The following is a description of a gene set: from publication Moserle L, Indraccolo S, Ghisi M, Frasson C, Fortunato E, Canevari S, Miotti S, Tosello V, Zamarchi R, Corradin A, Minuzzo S, Rossi E, Basso G, Amadori A (PMID 18632618) The side population (SP), recently identified in several normal tissues and in a variety of tumors based on its ability to extrude some fluorescent dyes, may comprise cells endowed with stem cell features. In this study, we investigated the presence of SP in epithelial ovarian cancer and found it in 9 of 27 primary tumor samples analyzed, as well as in 4 of 6 cultures from xenotransplants. SP cells from one xenograft bearing a large SP fraction were characterized in detail. SP cells had higher proliferation rates, were much less apoptotic compared with non-SP cells, and generated tumors more rapidly than non-SP cells. We also investigated the effects of IFN-alpha, a cytokine that has widely been used to treat solid tumors, on epithelial ovarian cancer cells and observed that IFN-alpha exerted marked antiproliferative and proapoptotic effects on primary cultures containing high numbers of SP cells. In vitro, IFN-alpha treatment invariably caused a dramatic reduction in SP size in tumor cell lines of different origins; moreover, IFN-alpha treatment of purified SP cells was associated with a distinctive change in their transcriptional profile. Gene therapy with human IFN-alpha resulted in regression of established tumors bearing a large SP fraction, which was not observed when tumors bearing low SP levels were treated. These findings could have relevant clinical implications because they imply that tumors bearing large SP numbers, albeit rare, could be sensitive to IFN-alpha treatment. Human Gene Set: MOSERLE_IFNA_RESPONSE Top genes up-regulated in ovarian cancer progenitor cells (also known as side population, SP, cells) in response to interferon alpha (IFNA). species: Homo sapiens, and this is the list of marker genes: CD274, USP18, CXCL10, IFI44L, SAMD9L, RSAD2, IFIT5, RTP4, STAT1, SAMD9 (sterile alpha motif domain containing 9), OAS2, CMPK2, HERC5, ZC3HAV1, MX1, RIGI, DDX60, TNFSF10, OASL, DDX60L, IFI44, IFIT3, IFITM1, IFIT1, GBP1, EPSTI1, IFIT2, OAS1, TRIM22, IFIH1, IFI16